Given this list of marker genes NRP2 (neuropilin 2), TREM2, MET, PLXNB1, PLXNA2, PLXNC1, NRP1, PLXND1, PLXNA4, PLXNB2, PLXNA1, PLXNB3, PLXNA3, here is a description of the gene set: Human Gene Set: GOMF_SEMAPHORIN_RECEPTOR_ACTIVITY Combining with a semaphorin, and transmitting the signal from one side of the membrane to the other to initiate a change in cell activity. species: Homo sapiens